The following is a description of a gene set: Mouse Gene Set: GOBP_SERINE_FAMILY_AMINO_ACID_METABOLIC_PROCESS The chemical reactions and pathways involving amino acids of the serine family, comprising cysteine, glycine, homoserine, selenocysteine and serine. studied in species Mus musculus, and this is the list of marker genes: Shmt2, Cbs, Ggt1, Gnmt, Scly, Agxt2, Psph, Mpst, Gcsh, Tha1, Phgdh, Gart, Gldc, Srr, Sephs2, Shmt1, Mthfd1, Ndp, Txnrd1, Cdo1, Gcat, Tdh, Agxt, Thnsl2, Glyat, Amt (aminomethyltransferase), Sephs1 (NCBI Gene Id 99323), Hao1, Cth, Sds (NCBI Gene Id 231691), Csad, Psat1, Sdsl, Baat